Given this list of marker genes Cdk11b (NCBI Gene Id 12537), Ubiad1, Agtrap (NCBI Gene Id 74834), Gm23318, Tnfrsf9 (tumor necrosis factor receptor superfamily, member 9), Masp2, Rpl22, Tmem52, Gm25880, Gm13133, Gm833, Morn1, Gm16333, Casz1, Gm13171, Gm13134, 4930589P08Rik, Dffb, Fv1, B230104I21Rik, Gm13648, Pex14 (NCBI Gene Id 97196), Slc2a7, Park7, Faap20, Gm22573, Gm13204, Tprg1l, Nmnat1, AW011738, Errfi1, Pank4 (NCBI Gene Id 97197, pantothenate kinase 4), Gm13093, Srm, Ccnl2, Gm13110, Hes3 (NCBI Gene Id 15207), Plekhg5, Agrn, Gm13203, Megf6, Atad3a, Cptp, Uts2, Rnf207, Gm13092, Fndc10, Gm13073, Ctnnbip1, Cenps, Rer1, Cep104, Mir5616, Icmt, Cort, Ube4b, Ttll10, Prdm16, Trmt112-ps2, Tmem201, Gm26036, 2510039O18Rik, Gm13201, Gm9506, Nadk, Gm25982, Tardbp, Ttc34, Smim1, Tnfrsf25, Tas1r3, Gpr157, Hes2, Angptl7, Hes5, Klhl21, Prkcz, Tnfrsf4, Disp3, Mmel1, Ski, Ssu72, Rpsa-ps12, Thap3, Rnf223, Gm13077, Slc25a33, Tnfrsf14, Ankrd65, Chd5, Slc35e2, Gm572, Dvl1, B3galt6, H6pd, Cfap74, Aurkaip1, Pex10, Camta1, Car6, Noc2l, Gm24002, Mad2l2, Gm13207, Mfn2, Per3, Clcn6, Nppa, Trp73, Gnb1, Gm13094, Gm13172, Nphp4, Prdm16os, Rbp7, Slc2a5, Acot7, Actrt2, Acap3, Zbtb48, Gm13205, Mxra8, Gpr153, Mir429, Ccdc27, Gm15969, Espn, Prxl2b, Isg15, Samd11, Vmn2r129, Mir200b, Vmn2r125, Mir200a, Ints11, Slc45a1, Gm13070, Tas1r1, Fbxo2, 9430015G10Rik, Gm13049, Clstn1, C1qtnf12, Sdf4, Mthfr, Kcnab2, Ube4bos1, Tmem240, Eno1, Mmp23, Mir7023, Pik3cd, Dffa, Lzic, Gm13112 (predicted gene 13112), Gm13090, 5830444B04Rik (RIKEN cDNA 5830444B04 gene), Ube2j2, Dnajc11, Ajap1, Gm13132, Pgd, Ube4bos3, Perm1 (PPARGC1 and ESRR induced regulator, muscle 1), Nol9, Plod1, Spsb1, Rere, Gm17029, Tnfrsf18, Mir34a, Rps15a-ps3 (ribosomal protein S15A, pseudogene 3), Gm23405, Plekhn1, Arhgef16, Gabrd, Wrap73, Vamp3, Mir7658, Gm13066, Phf13, Gm23303 (predicted gene, 23303), Gm13067, Atad3aos, Mib2, Lrrc47, Miip, Exosc10, 1500002C15Rik, Gm24381, A430005L14Rik, Gm47252, Mrpl20, 1700045H11Rik, Pusl1, Draxin, BC039966, Mir7022, Chchd2-ps, Gm16008, Gm16023, Nppb, Mtor, Tmem274, Plch2, Kif1b, Fbxo44, Fbxo6, Tmem88b, Vwa1, here is a description of the gene set: studied in species Mus musculus Mouse Gene Set: chr4E2